Given this list of marker genes Drd4, Adrb3, Rnls, Adra2a, Adra2c, Adra2b, here is a description of the gene set: Binding to epinephrine, a hormone produced by the medulla of the adrenal glands that increases heart activity, improves the power and prolongs the action of muscles, and increases the rate and depth of breathing. It is synthesized by the methylation of norepinephrine. Mouse Gene Set: GOMF_EPINEPHRINE_BINDING studied in species Mus musculus